Given this list of marker genes CC2D1A, RASAL2, ARHGEF9, PRDM8, ZBTB41, VASH2, ITGA9, NTN4, RAP1A, RDX, CEP350, SLC24A3, ESR1, CDCA7, ABCA1 (ATP binding cassette subfamily A member 1), INTS6, MEF2C, NOVA1, DNAJC13, JAZF1, KBTBD8, TMUB2, CREBRF, BAZ1A, UBE2B, KMT5B, MICALL1, UBFD1, LDOC1, PGBD5, TENT5C, UHMK1, SIK1, SNX21, PAK5, AEBP2, LETMD1, ABR, ATXN7L2, RABEP1, CCND1, RAB11A, PURB, MTMR3, JPT1, CELF2, SAR1B, RASSF2, JADE2, ATAD2, CRTC2, KMT2A, ATP2B2, TRAPPC14, CDH2, OSBPL8, UNC45A, FLT1, DNAJA2, RALGDS, CREB5, RALGPS2, NFIB, PPP2R3A, MYRF, MKRN1, NR4A3, CDH4, VLDLR, KLHL18, RBFOX1, YTHDF3, UBR3, WNT5A, PAPOLA, ZNF654, CPD, RB1CC1, TUBG1, DDX3X, AK2, ZFP91, RABGAP1, SLC38A2, PBX3, ZKSCAN1, MECP2, CCND2, PRDM4, ZFPM2, TARDBP, VGLL3, RICTOR, ZBTB11, ZNF180, WDR37, CXXC5 (NCBI Gene Id 51523), CDK19, MACROH2A1, TMEM87A, USP42, LEFTY1, CERS3, ITFG1, APP, ZFYVE26, TEX30, SP1, ZBTB26, TNFAIP1, RBL1, DERL2, SEPTIN2, NT5C3A, FAM13C (NCBI Gene Id 220965), SIMC1, FGD5, NAPEPLD, IGF2BP1, COL4A3, PRKACB, UBE2Q2, NHSL3, GATAD2B (GATA zinc finger domain containing 2B), MAP3K14, CDC25B, MBNL2, ARF1, OCRL, ASF1B, EDNRB, PCGF5, ARID4A, LHX6 (LIM homeobox 6), IL6ST, RNF6, SYNC, PANK2, TMCO2, GRHL2, VAMP3, ASF1A, RC3H1, AGFG2, ANO6, XYLT1, MEX3C, RPS6KA5, SLC22A23, CDKN1B, DDHD1, ZNF385A, AP3M1 (adaptor related protein complex 3 subunit mu 1), MED12L, RFX4, ARHGEF17, HIVEP3, ATF6B, EMX2, MTUS1, LCOR, FBXW11, RARB, SENP1, VANGL2, EPAS1, VSX1, TMTC1, RGL1, ADCYAP1, CFL2, IQSEC2, HSPA14, CNOT6, HACD2, TOX, UBXN1 (NCBI Gene Id 92151), SUGP1, ZDHHC17, TSHZ3, CAMK2N1, RAPGEFL1, YOD1, MMP24, FIGN, TNRC6B, ZNF800, PPP4R3A, SLITRK3, TLCD3A, OPCML, RIC8B, CYP26B1, ZNF462, WDR26 (WD repeat domain 26), C19orf48P, OLFM3, GAB2, DPP4, KPNB1, DLL4, SPRED1 (NCBI Gene Id 161742), LMBR1L, KIF3B, FRAS1, NR2C2 (NCBI Gene Id 7182), NEK9, PLXNA1, PAN3, RAB22A, PWWP3B, TET1, KCNMA1, KMT2E, TIPARP, TBL1XR1, LYPD6, SLC6A9, RGMA, BACH2, ZBTB47, IRF2, DCAF6, SS18L1, PLAG1, SPTLC1, PRC1, ZNFX1, ARID4B, PICALM, LMO3, YTHDC1, ZNF436, MINK1, MNT, TFAP4, FNDC3A, MTCH2, here is a description of the gene set: studied in species Homo sapiens Genes having at least one occurence of the motif AAGCACT in their 3' untranslated region. The motif represents putative target (that is, seed match) of human mature miRNA hsa-miR-520f (v7.1 miRBase). Human Gene Set: AAGCACT_MIR520F